The following is a description of a gene set: This event has been computationally inferred from an event that has been demonstrated in another species.<p>The inference is based on the homology mapping from PANTHER. Briefly, reactions for which all involved PhysicalEntities (in input, output and catalyst) have a mapped orthologue/paralogue (for complexes at least 75% of components must have a mapping) are inferred to the other species. species: Mus musculus part of: Iron uptake and transport Reactome Pathway: Transferrin endocytosis and recycling electronically inferred by orthology from the curated human pathway, and this is the list of marker genes: Atp6v1e2 (NCBI Gene Id 74915), Tfr2, Atp6v0e, Atp6v0d1, Atp6v1g3, Atp6v0c, Atp6v1a, Hfe, Atp6v1g2, Atp6v1f (NCBI Gene Id 66144), Tcirg1, Steap3, Atp6v0e2, Atp6v0a4 (NCBI Gene Id 140494), Atp6v1c2, Mcoln1, Trf, Atp6v0a1, Atp6v1d, Atp6ap1